The following is a description of a gene set: Abnormality of venous physiology Human Gene Set: HP_ABNORMALITY_OF_VENOUS_PHYSIOLOGY An anomaly of venous function. species: Homo sapiens, and this is the list of marker genes: BMPR2, TERC, F5, JAK2, TERT, HFE, PIGA, TINF2, BMP6, CD55, MYH7